Given this list of marker genes CHMP5, LRCH3, WDR11, DXO, NMI, ZNF652, CREB3L2, MAP4K3, HLA-DOB, KDM7A, TRIM5, BBS4, D2HGDH, MIEN1, GPR18, CDKN1B, APLF, TUBGCP6, ANXA1, ECH1, KCTD20, TNFRSF18, EVI2B, MTMR3, TRMU, NCF1, CAMKMT, LRRC61, EXOC7, KIZ, NDUFS2, DPM3, PSMB8, ZNF318, KIFBP, PTPN18, ACP6, LY6D, TCEA3, BCL7A, MMUT, PHF21A, PHF14, CD47, RFC2, RNF141, PAPSS2, NAA38, CYP2R1, ALG6, CNTRL, ITGB3BP, IRF2, PHKA1, PPT1, NAP1L1, GDI2, MCCC1, SH3TC1, SEPTIN9, NME7, IDH2, SMARCAL1, RBM43, DOCK8, TMCO1, MS4A1 (NCBI Gene Id 931), KYNU, SHLD1, SMIM20, RFC5, MAP3K3, METTL8, TCF3, KLHL24, SLC14A1, CNRIP1, RWDD2A, ARID5A, CYLD, VPS13B, BFSP2, APPL2 (NCBI Gene Id 55198), RNF167, KCNA3, DLGAP5 (NCBI Gene Id 9787), CDK5RAP2, FES, COMMD4, CKLF, TSPYL4, FCSK, GNB2, SETD2, HERC2, CAPN1, FH, FANCG, PHKB, ARHGAP9, NOD1, SMARCA2, PTPRC, ZNF414, EP300, PTCD2, GTF3A, PDCD4, EAF2, B3GLCT, PHYHD1, NDUFB11, IFIT3, FAM117A, CABLES2, HSDL2 (NCBI Gene Id 84263), GPI, ZBTB4, SMAGP, CDK2AP2, CDKN3, PHC3, SUOX, IFT22, CETN2, AKNA, SPICE1, CYTH1, STXBP4, DNMBP, ANKZF1, KIAA0930, ZFP90, CEP162, LY86, LCLAT1, DYNLT3, RIPOR2, TMED3, TLR4, IVD, MEAK7, TMEM184C, CLCC1, RCHY1, SPC24, KLF3, SERINC3, N4BP2, L3MBTL3 (NCBI Gene Id 84456), NEDD4, RDH12, TMEM63A, H2AC25, CCDC66, ING1, VPS41 (VPS41 subunit of HOPS complex), ARHGAP45, CCDC12, GPD1L, MPEG1, DENND1B (NCBI Gene Id 54530), HSH2D, BNIP3L, BSDC1, SLC35C1, FLI1, DUSP19, CREB1, CRADD, AGO4, CHST12, PECAM1, GMNN, OTUB2, UNC119, CEP95, SH3YL1, CPNE5, IFT25, CCDC82, RASSF4 (NCBI Gene Id 83937), MX1, COG1, HPGD, NAPG, CELF2, PAGR1, DCLK2, TMEM14A, OXR1, RNF213, SMIM19, C9orf85, PADI2, NAE1, BACE1, HAUS5, CDC14A, SUSD3, here is a description of the gene set: Human Gene Set: GSE22919_RESTING_VS_IL2_IL12_IL15_STIM_NK_CELL_DN from publication Smith MA, Maurin M, Cho HI, Becknell B, Freud AG, Yu J, Wei S, Djeu J, Celis E, Caligiuri MA, Wright KL (PMID 20944005) Genes down-regulated in NK cells: fresh versus stimulated with IL2, IL-12 and IL15. We used Affymetrix expression arrays to determine changes in gene expression associated with activation of human NK cells mediated through treatment with cytokines IL-2, IL-12 and IL-18 over a 24 hour period. species: Homo sapiens